Given this list of marker genes HYAL1, SON, CAMTA1, KMT2A, COL5A1, IFITM5, here is a description of the gene set: Human Gene Set: HP_HYPEREXTENSIBILITY_AT_ELBOW species: Homo sapiens Hyperextensibility at elbow The ability of the elbow joint to move beyond its normal range of motion.